The following is a description of a gene set: species: Homo sapiens Human Gene Set: GOBP_PLATELET_DERIVED_GROWTH_FACTOR_RECEPTOR_ALPHA_SIGNALING_PATHWAY The series of molecular signals initiated a ligand binding to an alpha-type platelet-derived growth factor receptor (PDGFalpha) on the surface of a target cell, and ending with the regulation of a downstream cellular process, e.g. transcription., and this is the list of marker genes: PHF14, PDGFA, CBL, IFT20, ADIPOQ, CBLB, PDGFRA